The following is a description of a gene set: Metabolism of water-soluble vitamins and cofactors studied in species Mus musculus Mouse Gene Set: REACTOME_METABOLISM_OF_WATER_SOLUBLE_VITAMINS_AND_COFACTORS, and this is the list of marker genes: Nmrk1 (nicotinamide riboside kinase 1, NCBI Gene Id 225994), Mccc1, Btd, Nt5e, Naprt, Cd38, Shmt2, Bst1, Aldh1l2, Pdzd11, Slc25a16, Acp5, Flad1, Mmaa, Pdxk, Dhfr, Slc25a19, Rnls, Nadk2, Pank4, Pcx, Mccc2, Mmab, Shmt1, Folr2, Mocs3, Nudt12 (NCBI Gene Id 67993), Pank2, Aldh1l1, Acaca, Abcd4, Slc19a2, Aox1, Nmnat1, Pank1, Slc5a8, Cblif (NCBI Gene Id 14603), Coasy, Mthfs, Rfk, Nmrk2, Nmnat3, Gsto2, Thtpa, Slc19a1, Mtrr, Mthfsl, Nadk, Slc2a1, Slc52a2, Slc2a3, Slc46a1, Lmbrd1, Nadsyn1 (NCBI Gene Id 78914), Slc25a51, Fasn, Mtr, Slc23a1, Tcn2, Slc52a3, Mthfd1l, Mmut, Abcc1, Ppcdc, Hlcs, Nmnat2, Ppcs, Tpk1, Cd320 (CD320 antigen), Nampt, Slc25a32, Mocos, Acacb, Mthfd2, Naxe, Pank3, Pnpo, Mthfd2l, Ldlrap1, Pcca, Lrp2, Fpgs, Enpp1, Pccb, Slc22a13, Cyb5a, Aasdhppt, Dcakd, Nnmt, Mmadhc, Mmachc (NCBI Gene Id 67096), Mocs1, Slc23a2, Gsto1, Cyb5r3, Slc19a3, Qprt, Mthfd1, Vnn1, Mthfr, Naxd, Nfs1, Slc25a42, Gphn, Slc5a6